The following is a description of a gene set: studied in species Homo sapiens Any process that stops, prevents, or reduces the frequency, rate or extent of the chemical reactions and pathways involving nucleotides. Human Gene Set: GOBP_NEGATIVE_REGULATION_OF_NUCLEOTIDE_METABOLIC_PROCESS, and this is the list of marker genes: TSPO, PPP2CA, SLC4A1, PRKACA, IER3, CDA, TP53, RD3, NCOR1, MIR675, TIGAR, PARP1, ALDOB, FIS1, FLCN, TRIM63, PID1, MTCH2, CBFA2T3, PPARA (NCBI Gene Id 84730), FBP1, ACTN3, PFKFB1, SIRT6 (NCBI Gene Id 51548), STAT3, NUPR1 (NCBI Gene Id 26471), ATP5IF1, DDIT4, HDAC4, GIT1